The following is a description of a gene set: Genes up-regulated in B lymphocytes versus CD8 T cells. studied in species Homo sapiens Dendritic cells (DCs) process and present self and foreign antigens to induce tolerance or immunity. In vitro models suggest that induction of immunity is controlled by regulating the presentation of antigen, but little is known about how DCs control antigen presentation in vivo. To examine antigen processing and presentation in vivo we specifically targeted antigens to the two major subsets of DCs using chimeric monoclonal antibodies. Unlike CD8+ DCs that express the cell surface protein CD205, CD8- DCs, which are positive for the 33D1 antigen, are specialized for presentation on MHC class II. This difference in antigen processing is intrinsic to the DC subsets and associated with increased expression of proteins associated with MHC processing. from publication Dudziak D, Kamphorst AO, Heidkamp GF, Buchholz VR, Trumpfheller C, Yamazaki S, Cheong C, Liu K, Lee HW, Park CG, Steinman RM, Nussenzweig MC (PMID 17204652) Human Gene Set: GSE6259_BCELL_VS_CD8_TCELL_UP, and this is the list of marker genes: RHOBTB3, ZNF704, SECTM1, UQCC4, HJURP, ZXDB, FZD7, SETDB2, DNAL4, TMEM51, CHRDL1, GPR68, DAXX, PADI4, GCSAML, PEMT, NPEPPSP1, BMF, KIF5C, KAT2B, EEIG1, CA8, ZNF395, CLDND1, CSTF3, RHOU, KCNAB2, ITGAL, ZNF528, NUDT11, NCF4, EPB41L3, TUBB2B, NYNRIN, FAM171A1, TTC39C, SLC7A11, TUBB2A, MMP14, LPXN, TIPARP, PRDX5, SMIM3, KIT, DAG1, CUL1, LRP5, LINC00301, STOM, SEPHS2, ETS2, INTS9, ADCY9 (adenylate cyclase 9), FUT7, WASF3, HS6ST1, ACBD6, YAE1, IGFBP4, NCOA3, CXXC5, SSH1, EXOSC10, CYP1B1, MTRF1, CEP131, RSAD2, STK10, KHNYN, BMP5, IRF2BPL, LDLRAD4, CD9, TMEM131L, LRRC4, MAPK6, INPP1, MICAL2, ZBTB21, SLCO4A1, FMNL1, TNS1, SCAND3, ARG2, AGA, TBC1D8, MAD2L2, PMS2P5, ZMIZ1, ANKRD13C, AJUBA, TACC1, RGL1, PARP2, CD109, RNF128, CCL2, AFG2B, CREB5, SOS1, GPR183, PPP2R5C, EEPD1, TNFSF14, PTCH1, BMPR1A, DAGLB, CLCN4, PIEZO2, EIF3H, TSC22D3, DDHD1, CYP1A1, CROCC, VDR, YPEL4, KIF26A, PGAP4, ZSCAN5A, WWC3, RFTN1, PLAU, HBEGF, ZNF557, RNF144A, JPH1, CABLES1 (Cdk5 and Abl enzyme substrate 1), NACC2, ZNF107, ARL4C, AHRR, TBC1D14, SYNJ2, L3MBTL3, FUCA1, BTG2, GLCCI1, CABP7, SIGLEC15, RGS10, PLCH2, DSCR4, ADCY6, NKAIN2, CEBPA, HAS3 (hyaluronan synthase 3), CCR7, PRSS23, GAD1, XYLT1, LINC01579, PWP1, POLL, ZBED1, HERC2, ELAC1, RAB38, PRKAG2, STON1, CMTM3, EGR1 (early growth response 1), GALNT2, MN1, ADAP1, MACC1, ZZEF1, CNR2, SLC17A5, LACC1, BAG3, SLC12A7, MEF2A, SIPA1L2, OSBPL1A, GPR146, MBP, POLR3D, PPIF, PKIA, GNG11, KATNB1, GPR45, SEMA4A (NCBI Gene Id 64218), CXCR2, HMGCL, DDIT4, DMTN, LRRC47, KRCC1, ZBTB4, CLN3, CEP19, ZNF622